The following is a description of a gene set: LPA-GNAQ/11-RhoA signaling pathway. Pathway ID: N01104. Pathway type: Reference. Pathway class: nt06135 Cytoskeletal regulation (viruses and bacteria). studied in species Homo sapiens Pathway Definition from KEGG: LPA -> LPAR -> (GNAQ,GNA11) -> ARHGEF12 -> RHOA Human Gene Set: KEGG_MEDICUS_REFERENCE_LPA_GNAQ_11_RHOA_SIGNALING_PATHWAY, and this is the list of marker genes: LPAR3 (lysophosphatidic acid receptor 3), GNA11, LPAR1, GNAQ, RHOA, ARHGEF12, LPAR2 (lysophosphatidic acid receptor 2), LPAR4, LPAR5